The following is a description of a gene set: Any process that decreases the rate, frequency, or extent of the orderly movement of an endothelial cell into the extracellular matrix to form an endothelium. species: Homo sapiens Human Gene Set: GOBP_NEGATIVE_REGULATION_OF_ENDOTHELIAL_CELL_MIGRATION, and this is the list of marker genes: SERPINF1, NR2F2, CSNK2B, MIR15B, HRG, APOE, MIR193A, MIR19B1, ITGB1BP1, PPARG, TNF, DLL4, ADGRB1, PATZ1, MIR361, MIRLET7B, SPRED1, MIR129-1 (NCBI Gene Id 406917), MIR16-1, MIR137, APOH, MIR133B (microRNA 133b), TGFB1, MIR505, MIR503, MMRN2, MIR205, KRIT1, ACVRL1, STC1, HMGB1, MIR206, MIR101-1, THBS1, ADAMTS9, FGF2, VASH1, MIR424, MIR200C, MIR196A1, HDAC5, MECP2, MIR24-1, MIR640, MIRLET7A1, MIR885, MIR221, MIR92A1, RHOA, MIR204, SLIT2, DAB2IP, MIR410, MEOX2, PDCD10, MMRN1, MIR495, PTPRM, STARD13, MIR21, ATP2B4, GADD45A, MIR494, DNAJA4, DCN, MIR10A, MIR26A1, MIR329-1, MIR29C, MIR200B, MIR492, MIR146A, CARD10, MIR20A, MIR22, GDF2, MIR320A, MEF2C, MIR212, JUP, MIR199A1, SP100, MIR132, MIR497, RGCC, SYNJ2BP, ANGPT4, NOTCH1, MIR2355 (NCBI Gene Id 100423036), SVBP, MIR15A, AGTR2, ROBO4, BMP10, MIR483, MIR149, CXCL13, ANGPT2, TBXA2R, KLF4 (NCBI Gene Id 9314), MAP2K5, MIR152